Given this list of marker genes DAAM1, CAMK1, RAF1, PFN4, DVL1, ACTR2, PFN1, GSK3B, PIK3CG, MYL1, MAPK1, FZD10, ACTA1, GRIA1, MYC, TGFA, CDKN1B, NEFL, FZD7, CBL, TMSB4X, ERBB4, SRC, NOS1, PFN2 (NCBI Gene Id 85837), NEFM, FZD3, FN1, FZD9, FZD8 (frizzled class receptor 8), GPX1, WNT16, SOD1, FZD6, PTK2, STAT5A, AXIN1, NCK1, CTNNB1, FZD1, PPP2CA, EGFR, NEFH (NCBI Gene Id 4744), JUN, PLCG1, ELK1, FZD4, SOS1, WNT11, GRB2, APC, RHOA, MAPK8, CDKN1A, MAP2K4, AKT1, PFN3, PAK1, FZD2, ERBB2, SHC1, MAP2K1, ROCK2, FZD5, ACTR3, MYLK, here is a description of the gene set: Human Gene Set: WP_PHYSICOCHEMICAL_FEATURES_AND_TOXICITYASSOCIATED_PATHWAYS species: Homo sapiens Physico-chemical features and toxicity-associated pathways